The following is a description of a gene set: The chemical reactions and pathways involving cysteine, 2-amino-3-mercaptopropanoic acid. Mouse Gene Set: GOBP_CYSTEINE_METABOLIC_PROCESS studied in species Mus musculus, and this is the list of marker genes: Gclc, Agxt, Cth, Mthfd1, Slc7a11, Cbs, Gclm, Csad, Ggt1, Cdo1, Mpst